Given this list of marker genes OMG, LRRTM1, CCDC14, LINC00310, ELAVL2, MYO18A, CDX2, ZNF385B, HCRTR2, LEMD2, FGF14, NRF1, FGF6, ZEB2, KIF13A, VWA1, GABRG1, MARCHF1, KRT222, CLIP1, HOXC5 (NCBI Gene Id 3222), HOXB6, HPSE2 (heparanase 2 (inactive)), GPM6A, CD93, CSRNP3, TMSB4XP4, FGF12, NECTIN1, DCX, CACNA1C, PLEKHA6, TLL2, VAX1, ADAMTS5, SMPX, EVX1, CNN3, MSX2, ETV6, CLUH, C1S, GRK5 (NCBI Gene Id 2869), PDE4D (phosphodiesterase 4D), FGD4, FOXG1, DDX17, NRK, GNAI1 (NCBI Gene Id 2770), SYNPR, DMD, MAFB, KCNA2, DNAH5, MYBPC1, EYA1, LDB2, KCTD12, HOXC4 (NCBI Gene Id 50712), GPR158, SRRM4, CDK19, SFRP2, IL10, GCDH, KLHL5, B3GNT7, ETV5, CADM1, VDR, PLD5, GABRA1, here is a description of the gene set: Genes having at least one occurrence of the highly conserved motif M166 YNTTTNNNANGCARM in the regions spanning 4 kb centered on their transcription starting sites. The motif does not match any known transcription factor binding site. from publication Xie X, Lu J, Kulbokas EJ, Golub TR, Mootha V, Lindblad-Toh K, Lander ES, Kellis M (PMID 15735639) Comprehensive identification of all functional elements encoded in the human genome is a fundamental need in biomedical research. Here, we present a comparative analysis of the human, mouse, rat and dog genomes to create a systematic catalogue of common regulatory motifs in promoters and 3' untranslated regions (3' UTRs). The promoter analysis yields 174 candidate motifs, including most previously known transcription-factor binding sites and 105 new motifs. The 3'-UTR analysis yields 106 motifs likely to be involved in post-transcriptional regulation. Nearly one-half are associated with microRNAs (miRNAs), leading to the discovery of many new miRNA genes and their likely target genes. Our results suggest that previous estimates of the number of human miRNA genes were low, and that miRNAs regulate at least 20% of human genes. The overall results provide a systematic view of gene regulation in the human, which will be refined as additional mammalian genomes become available. studied in species Homo sapiens Human Gene Set: YNTTTNNNANGCARM_UNKNOWN